The following is a description of a gene set: An abnormality of the conduction of electrical impulses by peripheral (motor or sensory) nerves. This finding is elicited by a nerve conduction study (NCS). Abnormality of peripheral nerve conduction species: Homo sapiens Human Gene Set: HP_ABNORMALITY_OF_PERIPHERAL_NERVE_CONDUCTION, and this is the list of marker genes: CADM3, LAMA2, RNF170, HK1, RAI1, CACNA1S, JPH1, EMILIN1 (elastin microfibril interfacer 1), SETX, ABHD12, IDUA, SUCLA2, RAB7A, SORD, SLC25A15, PEX6, ATP7B, MPZ, ATL1, ERCC3, MEGF10, FBXO38, KCNJ18, VCP (valosin containing protein), DNAJC3, EGR2, PRX, KIF1A, TBCK, SPG21, POLG, SPTLC2, SLC5A7, PSAP, GARS1, NOTCH2NLC, LTBP3, UQCRC1, YME1L1, GJC2, ALS2, GABRA3, GJB1, HPDL, SBF1, HSD17B4, IGHMBP2, MPV17, GALC, FLVCR1, TBC1D20, CYP27A1, PLA2G6, MORC2, DNM2, PMP22, SUMF1, GFM2, ARSA, MYH14, SAMD9L, LMNA, CCT5, SOX10, YARS1, SH3TC2, NALCN, PRPS1, TRPV4, FGD4, LITAF, FIG4, UBA1, DEGS1, FBN1, DCAF8, CEP126, LRSAM1, ARHGEF10, SLC12A6, SNAP29, COL6A1, NEFL, ERCC8, ATXN1, ITPR3, SPTLC1, RRM2B, BSCL2 (BSCL2 lipid droplet biogenesis associated, seipin), SIGMAR1, WNK1, MTRFR, NDRG1, ATXN10, MFF, ERCC6, SCN9A, VPS13A, VAMP1, REEP1, SACS, KARS1, DHH, CHCHD10, ERCC4 (NCBI Gene Id 7509), ATP11A, HSPB8, NTRK1, ATL3, NEU1, TRIM2, PTRH2, DNAJB6, AARS1 (alanyl-tRNA synthetase 1), PDK3, MTMR2, SCP2, SPTAN1, CTDP1, CNTNAP1, HYCC1, TFG, PNKP, MFN2, FXN, RETREG1, TYMP, KIF1B, DHX16, MATR3, SYT2, GDAP1, PRDX3 (NCBI Gene Id 29017), PNPT1, LIG3, NGLY1, PLEKHG5, HSPB1, PMP2, PLP1, RFC1, NFASC, SBF2, CPLANE1, TPI1, AIFM1, LYST, TDP1, MED25, FBLN5